Given this list of marker genes SLC8A3, SLC8A1, SLC24A5 (NCBI Gene Id 338402), SLC24A1, SLC8A2, SLC24A2, SRI, CALM1, SLC24A4, SLC24A3, SLC8B1, here is a description of the gene set: Reactome Pathway: Sodium/Calcium exchangers part of: Metal ion SLC transporters species: Homo sapiens Calcium ions are used by cells as ubiquitous signalling molecules that control diverse physiological events. Three mammalian gene families control Ca2+ transport across plasma membranes and intracellular compartments (Lytton J, 2007). They are the Na+/Ca2+ exchanger family designated NCX (SLC8) (three members NCX1-3) (Quednau BD et al, 2004), the Na+/Ca2+-K+ exchanger family designated NCKX (SLC24) (five members NCKX1-5) (Schnetkamp PP, 2004) and a Ca2+/cation exchanger (NCKX6, NCLX) whose physiological function remains unclear.